Given this list of marker genes ALKBH4 (NCBI Gene Id 54784), KCNE5, KRT31 (NCBI Gene Id 3881), PLEKHH2, RRN3 (NCBI Gene Id 92636), BLTP3A, PDE8B, GALNTL6, DDX3Y, ARHGAP8, TTC7B, CHP1, DCAF1, PATZ1, PRICKLE2, ADIPOR1, TBX18, FAM47E, COPS2, TVP23C, PRR5-ARHGAP8, PTPRS, SMG1, CLECL1P, ALG2, DDX3X, GREM1, WIPF1, TSPAN33, PDF, PIAS1, CALN1, MIB1, TRIB2, REPS2, ST6GALNAC3, NRXN1, TVP23B, PFN2, FBXO41, KAT6B, ARHGEF18, IRF2BP2, CLEC16A, ABCB5, CFL2, TFG, CAPS2 (NCBI Gene Id 84698), KHDC4, CCDC6, DRD2 (dopamine receptor D2), ARHGEF5, TRPS1, HNRNPK, TMEM263 (NCBI Gene Id 90488), PGK1, SYNJ1, FOXA2, here is a description of the gene set: from publication Chen Y, Wang X (PMID 31504780) Genes predicted to be targets of miRBase v22 microRNA hsa-miR-4480 in miRDB v6.0 with MirTarget v4 prediction scores > 80 (high confidence targets). Human Gene Set: MIR4480 species: Homo sapiens